Given this list of marker genes Kat2a (NCBI Gene Id 76912), Smc5, Nat8, Smo, Nat8f7, Kif3a, Kat2b, Bag6, Atat1, Shh, Nat8f1, Ep300, Nat8b-ps, Kat7, here is a description of the gene set: The addition of an acetyl group to a non-terminal amino acid in a protein. Mouse Gene Set: GOBP_INTERNAL_PROTEIN_AMINO_ACID_ACETYLATION studied in species Mus musculus